Given this list of marker genes MMP2, FOXA1, GLI1, SOX9, SHH, PSAPL1, FGFR2, SFRP1, SERPINB5, STAT5A, FRS2, RARG, NKX3-1, FEM1B, BMP7 (bone morphogenetic protein 7), HOXA13 (NCBI Gene Id 3209), HOXA11, TP63, HOXA9, ESR1, NOG, SMARCC1, BMP4, AR, HOXA10, ALOX15B, WNT5A, RARA, STK11, FGF10, UBE3A (NCBI Gene Id 7337), TNC, HOXD13, CYP7B1, IGF1, HOXB13, PTCH1, PRLR, SERPINF1, CTNNB1, SULF1, CYP19A1, CRIP1, NOTCH1, EAF2, PLAG1, PSAP, ID4, WDR77, CDKN1B, FKBP4, here is a description of the gene set: Human Gene Set: GOBP_PROSTATE_GLAND_DEVELOPMENT The process whose specific outcome is the progression of the prostate gland over time, from its formation to the mature structure. The prostate gland is a partly muscular, partly glandular body that is situated near the base of the mammalian male urethra and secretes an alkaline viscid fluid which is a major constituent of the ejaculatory fluid. studied in species Homo sapiens